Given this list of marker genes Tmem59, Yipf1, Sgms1, Golga5, Yipf6, St6gal1, B4galt1, St3gal1, Yipf2, Hid1, here is a description of the gene set: studied in species Mus musculus The Golgi cisterna farthest from the endoplasmic reticulum; the final processing compartment through which proteins pass before exiting the Golgi apparatus; the compartment in which N-linked protein glycosylation is completed. Mouse Gene Set: GOCC_GOLGI_TRANS_CISTERNA